The following is a description of a gene set: studied in species Mus musculus electronically inferred by orthology from the curated human pathway part of: Innate Immune System Reactome Pathway: Advanced glycosylation endproduct receptor signaling This event has been computationally inferred from an event that has been demonstrated in another species.<p>The inference is based on the homology mapping from PANTHER. Briefly, reactions for which all involved PhysicalEntities (in input, output and catalyst) have a mapped orthologue/paralogue (for complexes at least 75% of components must have a mapping) are inferred to the other species., and this is the list of marker genes: S100b (NCBI Gene Id 20203), Ager, Hmgb1